Given this list of marker genes ADAM8, BBC3, TP53, ZC3H8, WNT5A, here is a description of the gene set: Human Gene Set: GOBP_POSITIVE_REGULATION_OF_THYMOCYTE_APOPTOTIC_PROCESS species: Homo sapiens Any process that activates or increases the frequency, rate or extent of thymocyte death by apoptotic process.